Given this list of marker genes Atp6v0c, Atp4b, Atp6v0b, Atp5f1e, Atp6v0a4, Atp12a, Atp4a, Atp5mg, here is a description of the gene set: Mouse Gene Set: GOMF_P_TYPE_PROTON_EXPORTING_TRANSPORTER_ACTIVITY studied in species Mus musculus Enables the transfer of protons from one side of a membrane to the other according to the reaction: ATP + H2O + H+(in) = ADP + phosphate + H+(out). These transporters use a phosphorylative mechanism, which have a phosphorylated intermediate state during the ion transport cycle.